Given this list of marker genes Sf3b4, Sf3a3, Snrpd3, Snrpb, Snrpe, Snrpd1, Snrpg, Snrpn, Sf3a1, Sf3b1, Sf3a2, Htatsf1, Sf3b2, Rbmx2 (NCBI Gene Id 72631), Phf5a, Snrpd2, Snrpb2, Sf3b5, Sf3b3, Snrpa1, here is a description of the gene set: studied in species Mus musculus A ribonucleoprotein complex that contains small nuclear RNA U2, a heptameric ring of Sm proteins, as well as several proteins that are unique to the U2 snRNP, most of which remain associated with the U2 snRNA both while the U2 snRNP is free or assembled into a series of spliceosomal complexes. Mouse Gene Set: GOCC_U2_SNRNP